The following is a description of a gene set: Human Gene Set: GSE7831_UNSTIM_VS_INFLUENZA_STIM_PDC_4H_DN CpG 1826 binds to Toll-like receptor (TLR)9, whereas influenza virus PR8 activates pDC via TLR7. Differential stimulation of pDCs is expected to result in unique activation mechanism(s) leading to a different phenotypically and functionally matured pDC We used microarrays to detail the global programme of gene expression underlying the maturation process of pDC activated with CpG 1826 and influenza virus PR8. We identified a distinct expression profile of upregulated immunomediators. from publication Iparraguirre A, Tobias JW, Hensley SE, Masek KS, Cavanagh LL, Rendl M, Hunter CA, Ertl HC, von Andrian UH, Weninger W (PMID 18029397) Genes down-regulated in plasmacytoid dendritic cells (4h): untreated versus influenza virus infection. species: Homo sapiens, and this is the list of marker genes: GALNT11, FKBP4, PACSIN1, OR4C3, EIF4G2, TBXA2R, LITAF, PSPH, DLST, TMED10, COX6A2, MAPKAPK2, FMOD, BCAS2, CD200, TANGO2, FES, SNX9, PIM2, FDPS, HMGCR, CTSD, POLD1, CDIP1, PPDPF, TWSG1, SH3BGR, ANKRD28, PARD6A, ZG16, RPS6KA1, SSR2 (signal sequence receptor subunit 2), GBA2, IPO11, CHRNB1, TRABD, WDR81 (WD repeat domain 81, NCBI Gene Id 780925), CADM1, FAM220A, AKR1E2, RNASE4, SMIM11, PPIC, LDHB, DGAT1, ECH1, PAFAH1B3, MEPCE, DNASE1 (deoxyribonuclease 1), TMEM229B (transmembrane protein 229B), KIF3C, DNAJC7, C8orf82, NUCB2, CLCN5, FKBP2, HAL, SELENOS, DAD1, LANCL1, ANAPC5 (NCBI Gene Id 51433), TXNDC5, PLAC8, CTPS2, AK3, DAP, SPINT1, DNM1L, HCRT, CA1 (NCBI Gene Id 759), CPSF2, RAC2, HMGN5, SLC44A4, TCF25, CDH10, LEFTY1, IRF1, S1PR4, RUNX2, SDHB, F5, CD28, SLPI, DCAF1, ETV1 (ETS variant transcription factor 1), RIPK1, BLNK, ADAMTS1, MTM1, FABP2, ATP1B1, NPTX2, GRN, SEC61A1, CHMP3, IRF8, IL7R (NCBI Gene Id 3575), EMP3, CTSB, NOTCH1, TSC22D1, GOLM1, ACIN1, MPDU1, MAP7D1, GNA15, RAMP1, DTX2, ASNS, PTGR1, CD48, ERBB3, ADORA2A, ZDHHC14, ITIH3, MYDGF, CTSV, GLRX3, TRIM25, HEMGN, RELL1, CCR5, GRK6, PCNP, PRSS8, HDAC5, NHP2, MAU2, SSBP2, DDIT4, SLC25A53, GNA11 (NCBI Gene Id 93626), TNFAIP8L1, AHNAK, UBXN4, PLTP, GLB1, TRIR, IGLC1, EMC3, INPP5K, MTF2, RPL12, LDB1, RDH11, MYO5B, CCR9, SERPINH1, EEPD1, ALAD, MAOA, PMS2, POLD2, OCIAD1, PKN2, PRDX2, PTCRA, SPIN1, SDHC, FLT3LG, MTDH, MRPL58, DDX1, SFRP1, CA2, HSPA4L, PPP1R14B, RHOH, NPC2, MED10, MAD2L1BP (MAD2L1 binding protein), SPIB, ATRAID, CHCHD3, MLEC, KLK4, GNE, DAG1, SERINC3, DNM1, PNCK, ADSS1, SLC7A6 (NCBI Gene Id 9057), TCEAL9, SFPQ, MCOLN2, VRK3, CFL2, PEX6, OXCT1 (3-oxoacid CoA-transferase 1), GTF2I, AARS1, NSDHL, ZFYVE19, XPO6, TSPAN8, SEC23B, MX1, GCOM1